Given this list of marker genes RUNX1, TOX, EOMES, RUNX3, TNFSF8, NCKAP1L, BCL2, IRF1, PSMB11, CBFB, LILRB4, ZBTB7B, SLC4A2, SOCS1, GPR18, here is a description of the gene set: species: Homo sapiens The process in which a relatively unspecialized T cell acquires specialized features of a mature CD8-positive, alpha-beta T cell. Human Gene Set: GOBP_CD8_POSITIVE_ALPHA_BETA_T_CELL_DIFFERENTIATION